Given this list of marker genes MLLT1, RAG1, DPP4, EPS8, KRAS, ADRA2A, NRARP, FOXP4, RELN, GAS2L3, CSTF1, TIFA, SSX2IP, PTER, NIBAN3 (niban apoptosis regulator 3), RBM14, SAPCD1, APC, TYMS, UHRF1, POMT1, SLC43A3, ZFPM1 (zinc finger protein, FOG family member 1), MARCKSL1, B3GNT8, STOM, HNRNPD, NFYA, PPM1F, GABPB1, PTGR1, SKP2, FOXM1, CAD, MTOR, TPM3, here is a description of the gene set: species: Mus musculus Genes from cluster 1: up-regulated in group C of tumors arising from overexpression of BCL2L1 and MYC in plasma cells. Multiple myeloma is an incurable plasma cell malignancy for which existing animal models are limited. We have previously shown that the targeted expression of the transgenes c-Myc and Bcl-X(L) in murine plasma cells produces malignancy that displays features of human myeloma, such as localization of tumor cells to the bone marrow and lytic bone lesions. We have isolated and characterized in vitro cultures and adoptive transfers of tumors from Bcl-xl/Myc transgenic mice. Tumors have a plasmablastic morphology and variable expression of CD138, CD45, CD38, and CD19. Spectral karyotyping analysis of metaphase chromosomes from primary tumor cell cultures shows that the Bcl-xl/Myc tumors contain a variety of chromosomal abnormalities, including trisomies, translocations, and deletions. The most frequently aberrant chromosomes are 12 and 16. Three sites for recurring translocations were also identified on chromosomes 4D, 12F, and 16C. Gene expression profiling was used to identify differences in gene expression between tumor cells and normal plasma cells (NPC) and to cluster the tumors into two groups (tumor groups C and D), with distinct gene expression profiles. Four hundred and ninety-five genes were significantly different between both tumor groups and NPCs, whereas genes were uniquely different from NPCs in tumor group C and genes were uniquely different from NPCs in tumor group D. Similar to human myeloma, the cyclin D genes are differentially dysregulated in the mouse tumor groups. These data suggest the Bcl-xl/Myc tumors are similar to a subset of plasmablastic human myelomas and provide insight into the specific genes and pathways underlying the human disease. from publication Boylan KL, Gosse MA, Staggs SE, Janz S, Grindle S, Kansas GS, Van Ness BG (PMID 17483317) Human Gene Set: BOYLAN_MULTIPLE_MYELOMA_C_CLUSTER_UP